Given this list of marker genes Cd1d1, Jak2, Il23a, Il12b, Il12a, Rasal3, Cd1d2, Il18, Hsph1, Tyk2, here is a description of the gene set: species: Mus musculus Any process that activates or increases the frequency, rate or extent of natural killer T cell activation. Mouse Gene Set: GOBP_POSITIVE_REGULATION_OF_NK_T_CELL_ACTIVATION